The following is a description of a gene set: Human Gene Set: REACTOME_SENSORY_PERCEPTION species: Homo sapiens Sensory Perception, and this is the list of marker genes: OR4D1, OR5AP2, OR2AG2, OR1E1, OR5H15, OR5H6, OR5H2, OR4F15, KCNQ4, OR4A15, OR2V2, OR5L1, OR51F1, OR4C5, TRPM4, OR10P1, OR2G2 (olfactory receptor family 2 subfamily G member 2), OR56B4, OR8A1, RBP3, OR2L8, OR1G1, GRXCR1, OR13C3, OR2T27, OR51D1, LPL, OR9Q1, OR4D2, OR2T1, RLBP1, RBP4, SCN3A, AKR1B10, RGS9, OR51F2, OR8D1, OR52E2, TAS2R43, OR1N2, TAS2R7, STRC, OR4C12 (olfactory receptor family 4 subfamily C member 12), OR4F6, SNAP25, OR51Q1, OR2A5, LHFPL5, OR5M3 (olfactory receptor family 5 subfamily M member 3), ADCY3, OR51E2, NMT2, OR14A2, PDE6B, OR1J2, OR5P3, OR13C2, OR1D4, LRP1, DHRS9, OR2J1, OR4B1, OR3A2 (olfactory receptor family 3 subfamily A member 2), PCLO, OR52A1, OR6C74, OR5H1, OR5AU1, OPN1LW, OR13A1, OR8U1, OR8I2, LRP8, SCN9A, GRK4, OR5AN1, SPTBN1, OR5AR1, OR5A2, SLC26A5, OR51I1, OR13H1, TAS2R50, OR12D3, PCDH15, OR2D2, BCO2, OR2F1 (NCBI Gene Id 26211), EPB41L3, OR11H4, OR51H1, OPN1MW, OR51V1, OR51B2, OR2T10, OR4F21, OR6N2, EPB41L1, OR10H2, CNGB1, OR10X1, TWF2, OR5B17, XIRP2, OR2A1, TAS1R1, OR7A10, OTOG, PLS1, GUCA1C, OR14J1, SDC1, GNAT3, GUCY2F, OR8B4, OR10G3, RIPOR2, OR52J3, LRP10, TMC1 (transmembrane channel like 1), OR2B3, OR10H5, OR7G1, OR1J1, OR1K1, OR14K1, OR10D3, KCNJ2, OR4X1, SCN2B, TAS2R38, OR5I1, CAPZA2, OR10R2, TMC2, LDLR, OR51A7, OR52E5, GUCA1B, KCNN2, OR51E1, CLPS, OR1Q1, OR8H2, OR6Y1, GPC6 (NCBI Gene Id 10082, glypican 6), CACNB2, OR10K1, OR13C8, CACNA1D, OR1L1, OR2B2, GPIHBP1 (glycosylphosphatidylinositol anchored high density lipoprotein binding protein 1), TAS2R20, OR10AC1, OR4M2, OR56A1, OR6T1, OR4K17, OR2T2, OR5D16, TRPM5 (NCBI Gene Id 29850), OR52B2, OR4A8, OR2A12, SCN1B, RGS9BP, SDC2 (syndecan 2), OR52D1, OR1E2, GPC3, LRP2, OR4C3, OR2V1, OR52B6, OR1S1, OR5AC1, RDH5, OR9A2, OR52E8, SCNN1B, OR5P2, EPS8, OR2A42, OR5B3, OR6V1, APOB, OR2AK2, OR2AP1, DNAJC5, OR1S2, OR10G6, OR4N2 (NCBI Gene Id 79320), OR10G8, CTBP2, USH1G, OR4D6, AWAT2, OR9A4, OR5K3 (olfactory receptor family 5 subfamily K member 3), OR6J1, RCVRN, OR4C11, OR2M5, RBP1, OR4K14, CYP4V2, OR8U3, OR7D4, OR2C1, SCNN1A, RDX, GRXCR2, OR6C4, TTR, OR2L13, PRKCQ, OR4K13, OR6C70, OR10H1, OR10Q1, GNAT1, OR2AE1, OR6C1, OR2AT4, OR6C76, OR6C2, OR5A1, OR5M9, OR2H1, RDH11, OR2T12, CLIC5, OR51T1, OR6K6, OR6C75, OR52E4, OR2C3, OR8G5, RDH8, OR9G4, OR4C13 (NCBI Gene Id 81311), OR3A1, OR7E24, TAS2R31, TAS1R3, OR1A1, CIB2, OR11H1, OR8D4, EBF1, OR5K2 (NCBI Gene Id 79288), SCN4B, DHRS3, OR56A5, OR2B6, OR4C15, OR5AC2, OR56A3, OR5G3, ABCA4, OR6C6, OR10AD1, OR5C1 (NCBI Gene Id 81364), SPTAN1, STX1A, OR5K1, PDE6A (phosphodiesterase 6A), TAS2R8, OR2A7, OR5T3, OR10G2, OR56A4, OR10A3, OR52K2, MYO7A, OR52R1 (olfactory receptor family 52 subfamily R member 1), AKR1C4 (NCBI Gene Id 1109), OR2D3, OR1B1, TAS2R41, OR4C16, OR52N1, TPRN, OR9G9, HSD17B1, OR52E1, LRP12, OR2L2, APOC3, RTP2, CNGA1, OR5V1, OR52K1, RDH12, OR6C68, OR8H1, OR8U8, OR11H7, LDB1, OR5B12, OR4D10, OR10A5, OR5T1, OR5J2, OR4Q2, OR8D2, OR2K2, OR6B2, CABP2, OR4F16, OR4F17, MYH9, APOA4, APOA1, TAS2R13, OR10G7, OR8J3, OR5T2, OR2G3, OR11A1, OR10J5, OR9I1, OR6K3, OR1M1, FNTA, OR1C1, ACTG1, MYO15A, METAP1 (methionyl aminopeptidase 1), SDC4, OR1L4, CHRNA10, OR2J2, OR52L1, OR10G9, OR5H14, OR14I1, RHO, OR10C1, OR4K5, BSN, MSN, OR4S1, LHX2, OR51A2, SAG, OR11G2, TAS2R5, OR2M3, RDH16, OR4N4, OR5B2, OR14A16, OR13C5, OR2T8, OR1D2, OR4L1, OR4C46, CAPZA1, OR5AS1, OR4E1, OR6M1, OR8J2, OR7C1, OR5M1, TRIOBP, OR10H3, OR6X1, OR10A6, REEP1, OR2AJ1, MYO3B, TAS2R16, OR13G1, OTOGL, OR7G3, OR52W1, USH1C, OR2M4, OR4D9, PRKCA, KCNMA1, TAS2R40, OR5F1, OR2T29, OR8H3, OR10J1, OR4X2, RTP1, MPP1, OR9G1, APOE, OR13J1, TMIE (NCBI Gene Id 259236), OR51A4, OR51L1, OR4D11, OR52A5, PPEF1, OR1L3, GUCA1A, SYP, OR2A25 (NCBI Gene Id 393047), OTOP1, OR2T4, GNB3, OR2T33, OR13C4 (NCBI Gene Id 79328), GPC4, OR52H1, CNGA2, OR1F1, OR2T7 (NCBI Gene Id 81458), ESPNL, OR10J3, OR10H4, OR13C9, CALM1, OR6A2, OR10V1, ACTB, ANO2, GPC5, ATP2B2, APOA2, OR8B8, OR6N1, OR1E3 (olfactory receptor family 1 subfamily E member 3 (gene/pseudogene)), OR1F12P, GNG13, OR5AK2 (olfactory receptor family 5 subfamily AK member 2), OR2T5, OR13F1, VAMP2, OR11H6, MYO1C, OR2J3, RBP2, OR51J1, TAS2R4, OR10A4, OR7G2, OR1L6, SDR9C7, BCO1, OR7A17, OR8S1, SYN1, OR4K15, TAS2R46, PJVK, OR5M11, HSPG2, OR6B3, OR9Q2, OR8K1, OR5L2, OR5K4, OR5D14, EZR, OR7A5, OR13D1, PLCB2 (NCBI Gene Id 5330), FSCN2, OR52N5, ATP2B1, OR10A7, OR52I1, CHRNA9, OR52N4 (olfactory receptor family 52 subfamily N member 4), LRRC52, OR5D13, OR4A47, OR4F3, OR51B5, OR2T6, PDE6G (NCBI Gene Id 5148), TAS2R14, METAP2, OR51S1, OR2W3, GPC1, OR5D18, NMT1, OR4M1, OR4K1, OR2T35, GNB1, OR2M2, OR6P1, TAS2R39, OR5M8 (olfactory receptor family 5 subfamily M member 8), OR1D5, GNGT1 (NCBI Gene Id 2792), APOM, OR7C2, AKR1C3, OR4P4, OR14C36, GUCY2D, OR5B21, OR7D2, OR1P1 (olfactory receptor family 1 subfamily P member 1 (gene/pseudogene)), FNTB, APOC2, OR8J1, OR2A2, OR4N5 (NCBI Gene Id 81122), OR2B11, OR2T34, OTOF, OR2S2, OR2F2, OR8K3, OR8B12, CASK, CALHM3, CAPZB, LRAT, OR2W1, GRM1, OR56B1, OR51G1, OR6F1, OR1N1, OR3A3, RPE65, OR4A5, TAS1R2, OR10S1, OR51B4, WHRN, OR4C45, GPC2, OR2G6, OR12D2, OR6C3, OR10T2, TAS2R10, OR4K2, OR8U9, OR51B6, KCNMB1, OR52N2, OR5AL1, RETSAT, OR11L1, OR52E6 (NCBI Gene Id 81265), OR4E2, OR4S2, OR4F29, OR6Q1, OR52I2, CAMKMT, PNLIP, GNB5, OR4F4, OR10Z1, PLB1, OR51I2, OR2A4, OR2AG1, OR51M1, OR1I1, CACNA2D2, ITPR3, OR2L3, AKR1C1, OR5M10, AGRN, CABP1, OR8B2, OR9K2 (olfactory receptor family 9 subfamily K member 2), SLC24A1, OR8K5, TWF1, OR2L5, OR4K3, OR10G4, MYO3A, OR10AG1, RAB3A, TAS2R3, OR2A14, GRM4, ESPN, OR4A16, OR6B1, OR4C6, OPN1SW, GRK7, GSN, OR2H2, OR1A2, SCNN1G, OR2T11, OR10K2, OR11H2, HSD17B6, OR52M1, OR6S1, EPS8L2, CDH23, SDC3, OR8B3, OR8G1, RDH10, OR1L8, SCN2A, OR52Z1P, OR10J4, OR2M7, CALHM1, TAS2R1, OR5W2, GRK1, OR10W1, OR2Y1, OR4Q3, CNGA4, GNAL, OR2Z1, OR10A2, OR51G2, OR4D5, TAS2R30, OR2T3, OR4F5, SLC17A8, STRA6, SCNN1D (NCBI Gene Id 6339), OR6C65, OR6K2, OR1J4